Given this list of marker genes CYP7B1, here is a description of the gene set: Bile acids are synthesised from cholesterol via two pathways - a classic neutral pathway involving cholesterol 7-alpha-hydroxylase (CYP7A1), and an acidic pathway involving 25-hydroxycholesterol 7-alpha-hydroxylase (CYP7B1). Defects in CYP7B1 can cause spastic paraplegia 5A (SPG5A), a neurodegenerative disorder characterised by a slow, gradual, progressive weakness and spasticity of the lower limbs. Defects in CYP7B1 can also cause Congenital bile acid synthesis defect 3 (CBAS3; MIM:613812), a disorder resulting in severe cholestasis, cirrhosis and liver synthetic failure. Hepatic CYP7B1 activity is undetectable. studied in species Homo sapiens Reactome Pathway: Defective CYP7B1 causes SPG5A and CBAS3 part of: Metabolic disorders of biological oxidation enzymes